The following is a description of a gene set: The chemical reactions and pathways involving fructose 2,6-bisphosphate. The D enantiomer is an important regulator of the glycolytic and gluconeogenic pathways. It inhibits fructose 1,6-bisphosphatase and activates phosphofructokinase. species: Homo sapiens Human Gene Set: GOBP_FRUCTOSE_2_6_BISPHOSPHATE_METABOLIC_PROCESS, and this is the list of marker genes: PFKFB1, PFKFB4, PFKFB3, PFKFB2, TIGAR